The following is a description of a gene set: studied in species Homo sapiens Enables the transfer of alpha-ketoglutarate from one side of a membrane to the other. Alpha-ketoglutarate (or oxoglutarate) is a compound with important roles in carbohydrate and amino acid metabolism, especially in transamination reactions and as a component of the TCA cycle. Human Gene Set: GOMF_ALPHA_KETOGLUTARATE_TRANSMEMBRANE_TRANSPORTER_ACTIVITY, and this is the list of marker genes: SLC13A3, SLC25A21, SLC22A7, SLC25A11, SLC13A2, SLC22A6